Given this list of marker genes Hal, Ido1, Hgd, Kmo, Il4i1, Haao, Qdpr, Acmsd, Kynu, Hdc (histidine decarboxylase), Amdhd1, Pah, Afmid, Fah, Tat (tyrosine aminotransferase), Tdo2, Ido2, Hpd, Uroc1 (NCBI Gene Id 243537), Gstz1, Ftcd, here is a description of the gene set: Mouse Gene Set: GOBP_AROMATIC_AMINO_ACID_FAMILY_CATABOLIC_PROCESS species: Mus musculus The chemical reactions and pathways resulting in the breakdown of aromatic amino acid family, amino acids with aromatic ring (phenylalanine, tyrosine, tryptophan).